The following is a description of a gene set: Reactome Pathway: Ubiquinol biosynthesis electronically inferred by orthology from the curated human pathway part of: Metabolism of cofactors studied in species Mus musculus This event has been computationally inferred from an event that has been demonstrated in another species.<p>The inference is based on the homology mapping from PANTHER. Briefly, reactions for which all involved PhysicalEntities (in input, output and catalyst) have a mapped orthologue/paralogue (for complexes at least 75% of components must have a mapping) are inferred to the other species., and this is the list of marker genes: Coq2, Coq7, Pdss2